Given this list of marker genes Isy1, Hyou1, Atg101, Rabl6 (RAB, member RAS oncogene family-like 6), Pea15a, Resf1, Pigp, P4htm (NCBI Gene Id 74443), Gm14121, Gm10308, Azin2, Marchf5, Eif4g3, Rpl24, Rpl7a, Exosc4, 1700045H11Rik, Gm26202, Trmt10a, Rpl36, Ppil1, Rpl5, Cmc1, Ube2q1, Hexim2, 1700113A16Rik, Hectd3, Gnb1l, Tmem135, Repin1, Kbtbd12, Vps52, Rasal3, Btg3, Cul2, Nt5c, Gabrb1, Ulk3, Slc25a29, Rpl9, Rpl35, Capn10, Gm15246, Mir1934, 1700001O22Rik (NCBI Gene Id 78205), D030028A08Rik, Uqcc4, Oard1, 1700112D23Rik, Snord55, Psmb4, Mrps15, Osbpl1a, Zfp830, Rad9b, U2surp, Sco2, Nr1d1, Tarbp2, Gkap1, Dnah1 (dynein, axonemal, heavy chain 1), Snf8, Glrx5, Obi1, Golga1, Knop1, Unc45a, Igf2r, Zfp707, Gm23301, Mpdu1, Atp6v1b2, Aagab, Evc2, Cep57, Actn2, Rpl7, Aldh3a2, Mvd, Dctd, Zfp783 (zinc finger protein 783), Gm11399, Cchcr1, Ribc2, Plagl2, Rpl19, Sfi1, Ccdc71, Pigg (NCBI Gene Id 433931), A330035P11Rik, Rpl3, Stag3, Susd1, Rpl29, Usp35, Parl, Zfp329, Nup107, Haglr, Ltbr, 9430037G07Rik, Man2c1, Nradd, Trib3, Pum1, Mtf2, Rpl11, Pgk1, Dnajc1 (DnaJ heat shock protein family (Hsp40) member C1), Btbd18, Gm13146, Clk4, Hormad1, Anapc11, Senp5, Pls1, Pmpcb, Cenpw (NCBI Gene Id 674508), Cdkn2a, Smc1b, Ntmt1, Rps14, Zfp438, Il10rb, Telo2, Cmtr1, Atp6v1a, Mllt1, Rmnd5a, Gpc2, Dcaf13, Ece1, Ptpdc1, Zfp668, Vps29, Prpf39, Meiosin, Rfc1, Plaat5, Hmgn1, Phkb, Tube1, Tmem131l, Nbea, 4933439C10Rik, Snrpb, Socs4, Gm15564, Serf1, Trip13, Slc26a2, Eif6, Rbm46os, Eid1, Ctsl, Rasef, Kctd3, Incenp, Hexa, Csnk2a1, Rack1, Med22, Pts, Trmo, Cyb561d1, Pom121, Bltp3a, Dhx40, Gm10190, Csnk1e, Smn1, Rab21, Cxxc4, Clptm1, Gm6089, Recql, Klhl26, Rpl34, Snord68, Gm20426, Taf7l, Rprd2, Snip1, Snord15a, Cobll1, Pradc1, Dzip1l, D330041H03Rik, 4632415L05Rik, Osbpl5, 5430416N02Rik, Oxsm, Mia3, Rpl36a, Zfp131, Spp1, Cox18, Wdr45b, Slc25a31, Hmgcr, Tada1, St7l, Lias, Lonrf1, Klhl35, Rpl8, Impdh1, Uqcc2, Grik2, Kin, Clpp, Prr19, Wdr77, Cep63, Zcwpw1, Sall4, Gabra4, Gm15545, Usp53, Ddx25, Brme1, Mfsd10, Cct6b, Rbm46, Tstd2, Cdkn1a, Ccnj (NCBI Gene Id 240665), Ube2v1, Ptprs, Phf20, Rps15a, Cdk6, 1110004F10Rik, Shcbp1l, Rpl12, Top6bl, Prpf3, Actl6a, Eif4a2, Prmt7, Rnf152, Mgmt, Eif4g1, Lnpk (NCBI Gene Id 99060), Cwc27, Ckap5, Ywhae, Mei1, 1700003G18Rik, Dmc1, Rps2, 4930445N08Rik, Atad3a, Klhl28, Slc35a1, Gm30238, Pfn4, Rpl37, Tasp1, Mir6236, Gm4755, Snhg15, 9430015G10Rik, Fam229b, Tcof1, Edrf1, Rpl10a, Bbx, Gm10840 (NCBI Gene Id 115487818), Brd2, Klf16, Ccdc12, Atp5f1c, Alkbh5, Prpf19, Tmco1, Trpm1, Zfp507, Fam76b, Gm26559, Zfp41, Lamtor1, Adal, Msh4, Adad2, Gde1, Ugp2, Cpsf1, Emc4, Ebag9, Trmt61b, Irak3, Pop5, Srek1ip1, Mir5122, Rpl6, Cinp, Snora9, Nr3c1, Mob3b, Psme1, Rpl35a, Uhrf2, Insig2, Snhg17, Vgll4, Hmg20b, Micu2, Abitram, Nr2f6, Mob1a, Ssbp4, Serbp1, Uchl1os, Alyref, Otud5, Rpl27, Xrn2, Tiprl, Zkscan17, Tmbim4, Pigm, Wdhd1, Atp5pb, Dhx9, Kbtbd6, Mir8104, Rpl7l1 (NCBI Gene Id 66229), Dab2, Kdm3a, Boll, Cct4, Mir345, Ppp2r2a, Uchl1, Gtf2h1, Gm26330, Msantd5l, Tm9sf2, Rps10, Tmem109, Akt3, Sgf29, Mir6516, 6330549D23Rik, Rsbn1, Vps16, Rpl13, Usp48, Hspbap1, Pold1, Rgmb, Capza1, Tomm70a, 4930473A02Rik, Gm26205, Hcfc2, Fscn1, Rps17, Rps8, Ap1ar, Macrod1, Iqck, Rbm8a, Eef1g, Tusc1, Bsg, Cstf1, Cntnap2, Ppp2r3d, Crem, Ap5s1, Bcas2, Ltv1, Adissp, Eif5a2, Cc2d1a, Bud31, Snora64, Tasor, Chchd6, Hnrnpdl, Pou2f1, Drg1, Naxd, Fkbp4, Mlh3, Tdrkh, Elmod2 (NCBI Gene Id 244548), Mov10l1, Ptp4a1, Ptk2, Plcxd2, Gm30270, Sh3bgrl2 (NCBI Gene Id 68100), Syce2, Rgs2, Zcwpw2, A330009N23Rik, Pogk, Rps18 (ribosomal protein S18), Retreg2, 4632404H12Rik (NCBI Gene Id 74034), Rpl41, Psmd3 (proteasome (prosome, macropain) 26S subunit, non-ATPase, 3), Rnf220, Prrc2a (proline-rich coiled-coil 2A), Brd9, 3110083C13Rik, Anapc13, Dgat1, Rnf227, Raver1, Msh3, Sel1l, Rcc1l, Akap11, Frat2, Rpl26, Naa50, Henmt1, Fam168b, Prxl2a, Nkiras1, 1700040D17Rik, E2f3, Rpl37a, Rpl31, Dnali1, Zfp850, Zkscan2, Zbtb40, Desi2, Tspan12, Ap1g1, Gm25296, Npdc1, Ncapg2, Actr1b, Macrod2, Pwp1, Spop, Azi2, Ppm1h, Il1rap, Dipk1a, Elp1, Mxd3, 4933424G06Rik, Zfp9, Sgms1, Glg1, Cdk5rap3, Ctsc, 4930519P11Rik, Sdc1, Lonrf2, Cops7a, Rpl17, Rnf212, Sphk2, Tjap1, Foxj3, Snora78, Gm10222, Hoxd1, 4930432B10Rik, Iqch, Rpl23, Gm10069, Alad, Vps51, Gm17634, Rfxap, Rnh1, Bcl7b, Lrsam1, Rnf168, Man2c1os, Trim28, Slc9a1, Yars2, Pigl, Rpl18, Gm23969, Gm23130, Hps5, Tdrd1, Csnk1d, Snhg20, Aurka, Klhl25, Zfp280d, Rps12, Mlf1, Rab8a, Fbxl5, Snora21, Fam20c, Noc2l (NOC2 like nucleolar associated transcriptional repressor), Gtf2ird2, Ccdc146, Arih1, Snhg9 (NCBI Gene Id 73474), Pcnx4, Gm11240, Mepce, Golt1b, Ankrd54, Snord58b, Adad1, Snora7a, Dis3, Glud1, Gm13238, Rpl39, Ubald1, Dennd6a, Hdac2, Selenow, Pus3, Ncor1, Gm26513, Fbxo30, Slc25a25, Zfp513, Senp1, Ung, A230060F14Rik, Zfyve16, Ncbp1, Cep250, Ubn2, Rexo2, Gas2, Enoph1, Gm15247, Plekhb2, Fbxo7 (NCBI Gene Id 97657), Rpl28, Gdpd5, Snord43, Rpl15, Gm16201, Sema5b, Gm22589, Dhx30, Gm15420, Psma1, Limd2, Rce1, Iqcg, Tcf19, Prrc2b, Armc8, Ddx39b (DEAD box helicase 39b), Atxn2l, Hccs, Errfi1 (NCBI Gene Id 74155), Atad3aos, Dpy19l2, Zfp866, Rps15, Efcab12 (NCBI Gene Id 212516), Optn, Prima1, Klhdc8b, Dctn4, Mir9-3hg, Zfp646, Ttc3, Cnppd1, Cog4 (component of oligomeric golgi complex 4), 6820408C15Rik, Frg2f1, 2310057M21Rik, Slc22a21 (NCBI Gene Id 56517), Cers2, Mttp, Prpsap1, Cops7b, Ddx10, Map3k10, Rbm39, 6330562C20Rik, Rad51, here is a description of the gene set: studied in species Mus musculus Mouse Gene Set: WDR5_TARGET_GENES Genes containing one or more binding sites for (Wdr5) in their promoter regions (TSS -1000,+100 bp) as identified by GTRD version 20.06 ChIP-seq harmonization. from publication Yevshin I, Sharipov R, Kolmykov S, Kondrakhin Y, Kolpakov F (PMID 30445619)